The following is a description of a gene set: Human Gene Set: PID_SYNDECAN_2_PATHWAY from publication Schaefer CF, Anthony K, Krupa S, Buchoff J, Day M, Hannay T, Buetow KH (PMID 18832364) Syndecan-2-mediated signaling events studied in species Homo sapiens, and this is the list of marker genes: SDCBP, MAPK3 (mitogen-activated protein kinase 3), MAPK8, RASA1, EZR, PRKCD, TNFRSF13B (TNF receptor superfamily member 13B), MMP2, TGFB1, CXCL8, HRAS, LAMA1, EPB41, ITGA5, CAV2, ITGA2, EPHB2, ITGB1, NF1, SRC, KNG1, FN1, RACK1, PRKACA, SDC2, MAPK1, CASP3, TRAPPC4, LAMA3, BAX, CSF2, RHOA, CASK